The following is a description of a gene set: Human Gene Set: GOMF_CHONDROITIN_SULFOTRANSFERASE_ACTIVITY Catalysis of the reaction: 3'-phosphoadenosine 5'-phosphosulfate + chondroitin = adenosine 3',5'-bisphosphate + chondroitin sulfate. species: Homo sapiens, and this is the list of marker genes: UST, CHST9, CHST12, CHST13, CHST3, CHST7, CHST11